The following is a description of a gene set: studied in species Homo sapiens Human Gene Set: KEGG_MEDICUS_REFERENCE_HEPARAN_SULFATE_DEGRADATION Pathway Definition from KEGG: HS -- IDS >> IDUA >> SGSH >> HGSNAT >> NAGLU >> GUSB >> GNS -> G02632 Heparan sulfate degradation. Pathway ID: N00615. Pathway type: Reference. Pathway class: nt06012 Glycosaminoglycan degradation., and this is the list of marker genes: GNS, SGSH (NCBI Gene Id 6448), IDS, IDUA, NAGLU, GUSB, HGSNAT